The following is a description of a gene set: The process in which a relatively unspecialized cell acquires specialized features of a glandular epithelial cell. A glandular epithelial cell is a columnar/cuboidal epithelial cell found in a two dimensional sheet with a free surface exposed to the lumen of a gland. species: Mus musculus Mouse Gene Set: GOBP_GLANDULAR_EPITHELIAL_CELL_DIFFERENTIATION, and this is the list of marker genes: Lhx3, Wdr77 (NCBI Gene Id 97079), Bmp2, Rxra, Hif1a, Spdef, Rarg, Slc9a4 (solute carrier family 9 (sodium/hydrogen exchanger), member 4), Pinc, Nr5a2, Ascl1, Nfib, Trp63, Fgf2, Pgr, Zfp800, Ext1, Foxa1, Fgfr2, Insm1, Yap1, Gpat4, Cav1, Sox9, Bhlha15, Otx2, Fgf8, Wnt4, Fzd5, Rarb, Prox1, Rara, Clcn2, Il31ra, Xbp1, Ctnnb1, Gata2, Gcm2, Notch1, Nkx6-3